Given this list of marker genes MAP1LC3B2, VPS33B, SCAF8, MICAL3, SNAPIN, SPTBN4, DMTN (NCBI Gene Id 2039), HSPA8, CAPZA1, UBQLN1, EIF5AL1, CAPZA3, VTA1, PIF1, GSN, NCKAP5, H2BC1, FGF13, RPL23, FAF2, CLTC, NAPB (NSF attachment protein beta), CHMP1A, HMGA1, MTRF1L, VIL1, CAPG, CHMP7, CCSAP, UVRAG, SH3BP1, WIPI2, CAMSAP2, SUPT16H, TNP1, NSF, CHMP2A, NAPA, TTBK2, SMARCB1, PEX2, CLN3, HEMK1, KATNB1, EIF5A, IGF1R, GFM2, ADD3, PYM1, EIF5A2, APC, KIF14, TRPV4, DNAJC6, VTI1B, DYRK3, SWAP70, PLEKHH2, SEMA5A, LAMP2, TNF, FLII, CFL2, GABARAPL2, CLEC16A, ATG14, MRPL58, MAP1A, EPG5, ATXN7, MTRFR, MICAL2, GAS2L1, TMOD4, DNAJC17, GAS2L2, ATAD2, ZMPSTE24, ARHGEF2, SVIL, MFSD8, PLEK, ASB2, EPS8, KIF2C, MYC, ELP6, PPP1CA, DSTN, CLASP2, RDX, BECN1, SLN, STX17, CCDC88C, KIF2B, LMOD2, CAPZA2, CRACD, MAP6D1, KIF24, PIK3CA, STMN1, CKAP5, PIK3C3, GSPT2, ATP2A2, SCAF4, GABARAPL1, RUBCN, SPTBN1, GABARAP, BNIP3, STMN3, KLC1, KIF19, CARMIL2, CALCOCO2, SMARCD2, CAPZB, VAMP8, SNAP29, ASPH, STMN2, SPTBN5, MTRF1, CIB1, HDGFL3, WASHC2C, RUBCNL, INSR (NCBI Gene Id 3643), SMAD7, CHMP4C, GAK, SMARCD3, AFG2B, CKAP2, OGFOD1, PEX10, CHMP6, KIF18B, TRIM21, ATAD2B, ACTN2, CHMP2B, ZFAND1, DDIT4, MAP1LC3C, GSPT1, TFIP11 (tuftelin interacting protein 11), SPEF1, CFL1, LMOD1 (leiomodin 1), KIF5B, CHMP3, MID1IP1, SSRP1, SPTBN2 (spectrin beta, non-erythrocytic 2, NCBI Gene Id 6712), CALM1, TRAF2, PPP1R10, ATG12, BMERB1, GABARAPL3, SPTB, SMARCA4, LIMA1, NES, SMCR8, AVIL (advillin), BBOF1, HDAC6, SPTAN1, PHF23, CHMP5, MCOLN1, TOM1, ARID2, TMEM39A, KIF18A, MAP1S, JMJD4, SMARCC2, SCIN, CLASP1, UBQLN4, NFE2 (NCBI Gene Id 4778), UPF1, VMP1, TECPR1, SYNJ1, KIF2A, TAOK1, MICAL1, VPS4A, ADD2, PEX12, TSG101, APC2, PDXP, WDR47, TRIOBP, TWF1, SNX14 (sorting nexin 14), MTPN (myotrophin), IST1, IRGM, LMOD3, SETX, NCKAP5L, EEF2K, PIK3R4, VAMP7, WNK1, H2AC25, SPECC1L, ETF1, LIX1L, FYCO1, SMARCD1, VCP, STMN4, SHFL, ABCE1, NAV3, VPS4B, VIPAS39, SMARCC1, ADRB2, VILL, KIF21A, DIAPH3, TMOD2, CHMP4B, F2RL1, CARMIL1, WDR1, TRIM54, GRWD1, TMOD1, SPAST (NCBI Gene Id 6683), VPS16, ARID1A, PEX5, PEX14, CHMP4A, AURKB, APEH, CHMP1B, SMARCE1, TMOD3, PPP1R9B, TWF2, MAP1LC3A, TBC1D25, LIX1, MAP1B, IRAK3, TPX2, SET, ATG5 (autophagy related 5), MAP1LC3B (NCBI Gene Id 81631), CHMP4BP1, SPTA1, VPS33A, MID1, ADD1, here is a description of the gene set: Human Gene Set: GOBP_PROTEIN_CONTAINING_COMPLEX_DISASSEMBLY species: Homo sapiens The disaggregation of a protein-containing macromolecular complex into its constituent components.